The following is a description of a gene set: studied in species Homo sapiens The gene expression program underlying the specification of human cell types is of fundamental interest. The study authors generated human cell atlases of gene expression and chromatin accessibility in fetal tissues. For gene expression, the study authors applied three-level combinatorial indexing to >110 samples representing 15 organs, ultimately profiling ~4 million single cells. The study authors leveraged the literature and other atlases to identify and annotate hundreds of cell types and subtypes, both within and across tissues. Our analyses focused on organ-specific specializations of broadly distributed cell types (such as blood, endothelial, and epithelial), sites of fetal erythropoiesis (which notably included the adrenal gland), and integration with mouse developmental atlases (such as conserved specification of blood cells). These data represent a rich resource for the exploration of in vivo human gene expression in diverse tissues and cell types. Human Gene Set: DESCARTES_FETAL_PANCREAS_SMOOTH_MUSCLE_CELLS Marker genes curated from the annotated cluster as represented in the Descartes Human Gene Expression During Development database. from publication Cao J, O'Day DR, Pliner HA, Kingsley PD, Deng M, Daza RM, Zager MA, Aldinger KA, Blecher-Gonen R, Zhang F, Spielmann M, Palis J, Doherty D, Steemers FJ, Glass IA, Trapnell C, Shendure J (PMID 33184181), and this is the list of marker genes: CBLN1, ACTA2, TLX1, CARMN (NCBI Gene Id 731803), LINC00989, LINC03056, LINC02237, SGCA, BMP5, NDUFA4L2 (NCBI Gene Id 56901), MUSTN1, THBS4, AVPR1A, LINC00702, GPR20, OR51E2, OR51E1, HIGD1B, NPTX1, CSPG4, ACTG1P25, RGS5, GJC1, CIDEA, AOC4P, FAM162B, SFN, CCDC3, AOC3, FOXF2, ANKRD20A11P, NTF3, SLC6A1, PLN, MYH11, SEPTIN4, ACTG2, DCLK3 (doublecortin like kinase 3), CASQ2